Given this list of marker genes Tsc22d1, Aasdh, Rtl6, Rnf166, Ifi209, Fblim1, Nr2c2, Cd151, Cluh, Prnp, Ppp1r15b, Sart3, Wdr7, Asb17, Emp2, Med29, Abcb9, Cdpf1, Hddc3, Nat10, Acyp1, Cmtm8, Nup188, Cbr2, here is a description of the gene set: Mouse Gene Set: CUI_MAST_CELL_M_CSF_RESPONSE_UP from publication Cui A, Huang T, Li S, Ma A, Pérez JL, Sander C, Keskin DB, Wu CJ, Fraenkel E, Hacohen N (PMID 38057668) Cytokines mediate cell-cell communication in the immune system and represent important therapeutic targets. A myriad of studies have highlighted their central role in immune function, yet we lack a global view of the cellular responses of each immune cell type to each cytokine. To address this gap, the authors created the Immune Dictionary, a compendium of single-cell transcriptomic profiles of more than 17 immune cell types in response to each of 86 cytokines (>1,400 cytokine-cell type combinations) in mouse lymph nodes in vivo. A cytokine-centric view of the dictionary revealed that most cytokines induce highly cell-type-specific responses. For example, the inflammatory cytokine interleukin-1β induces distinct gene programmes in almost every cell type. A cell-type-centric view of the dictionary identified more than 66 cytokine-driven cellular polarization states across immune cell types, including previously uncharacterized states such as an interleukin-18-induced polyfunctional natural killer cell state. species: Mus musculus Genes positively differentially expressed in cell type: Mast cell upon treatment with cytokine: M-CSF in mouse lymph nodes in vivo.